The following is a description of a gene set: Aryl hydrocarbon receptor pathway studied in species Homo sapiens Human Gene Set: WP_ARYL_HYDROCARBON_RECEPTOR_PATHWAY_WP2586, and this is the list of marker genes: ARNT, RAF1, SRC, LPL, PTGS2, AHRR, FGF21, CYP1A1, CYP1B1, HRAS, HSP90AA1, KRAS, NF1, EGFR, NQO1, RET, AIP, PLAGL1, EP300, GCLC, MYC, CDK2, TNF, MAPK1, PSRC1, RB1, NFKB1, KLF6, CD36, NCOR2, CDC37, MAP2K1, RELA, NRIP1, VEGFA, CDKN1A (cyclin dependent kinase inhibitor 1A), CDKN1B, E2F1, ESR1 (estrogen receptor 1), NRAS, CYP1A2, AHR, NFE2L2, NCOA7, CCL1, HPGDS